The following is a description of a gene set: studied in species Homo sapiens Any process that modulates the frequency, rate, or extent of neutrophil chemotaxis. Neutrophil chemotaxis is the directed movement of a neutrophil cell, the most numerous polymorphonuclear leukocyte found in the blood, in response to an external stimulus, usually an infection or wounding. Human Gene Set: GOBP_REGULATION_OF_NEUTROPHIL_CHEMOTAXIS, and this is the list of marker genes: BST1, CD74, C5AR1, TIRAP, NCKAP1L, PERP (NCBI Gene Id 64065), SLIT2, JAM3, DNM1L, CCL19, CXCL8, CAMK1D, THBS4, RAC2, RIPOR2, XCL1, MOSPD2, MDK, MPP1, MCU, DAPK2, CCR7, LBP, C5AR2, C1QBP, TNFAIP6, MIR223, C3AR1, EDN1, CCL21, RAC1, DPP4, IL23A